Given this list of marker genes SPO11, IHO1, REC114 (REC114 meiotic recombination protein), HORMAD1, MEI4, ANKRD31, TOP6BL, MRE11, here is a description of the gene set: Human Gene Set: GOBP_MEIOTIC_DNA_DOUBLE_STRAND_BREAK_FORMATION species: Homo sapiens The cell cycle process in which double-strand breaks are generated at defined hotspots throughout the genome during meiosis I. This results in the initiation of meiotic recombination.